Given this list of marker genes YOD1, RPN2 (NCBI Gene Id 6185), PSMB6, CORO1B, RPS26, TSPAN13, CTRB2, RUBCNL, NKAPD1, AKAP1, MYBBP1A, GID4, SNRPB2, RPE, CD1D, ERAP1, SLC5A2, U2AF1, GM2A, JADE3, CERS6, TUT4, GIMAP5, PDGFRA, PAICS, BAX, TAGLN2, SCGB2A2, AGRN, CD177, H2BC6, BTNL2, NDUFC2, BID, ZNHIT3, ANKRD17, TANC2, TCOF1, GATA6, CYP3A43, RGS12, GPA33, GAK, NF2, ACTR1A, PDLIM1, GZMA, GBE1, PABPN1, RFX2, ISG20L2, PEF1, DNAJB4, DKC1, CSK, KIR2DS5, CROCCP3, WRN, HDAC2, RAD23A, MAGED2, TOB1, ARR3, PLAGL1, GNAI1, LIF, NCF1C, TFPI, KCTD5, YARS1, BBLN, ADRB3, AP3S2, TENM1, SERPINC1, DAAM1, GTPBP1, EEF1E1, NREP, COX6C, FRMD4A, ZKSCAN7, RANBP10, RNASET2, H1-2, SIDT2, PLAC8 (NCBI Gene Id 95621), IPPK, MARCKS, H4C11, PRRC2B, CBX2, LINC01587, FAM3C, UBB, NR0B2, DGCR5, OTUD4, IFITM3 (interferon induced transmembrane protein 3), SMARCC1, GCFC2, NR2E1, EHD4, CARF, TCF4, EML2, CD19, KDM4A, TTK, BRD3OS, KAZN, BCL11A, HEG1, ADIPOQ, UPP1 (uridine phosphorylase 1), ARHGEF5, FGD1 (NCBI Gene Id 2245), LCN1, PRR36, SCGB1D2, CPEB3, MAST4, TFDP1, GAL3ST4, KRT38, HLA-DQA1, TMEM33, MAGEH1, COL19A1, IFNGR2, OR7E36P, CHST2, PTPRT, PCMTD2, P4HA1, KRT12, OSBPL11, PLOD2, SH2D1A, MCL1, NEURL1, BACH1, H2BC12, NOP10, PRELP, PI4KB, TMEM45A, HTR2B, SDHC, ATG4B, ZNF493, DPYD, SMC4, HSPH1, GGCT, HPGD, ZBTB39, IVD, PLEKHF2, DAZL, HSPA1A, TNFAIP3, RBX1, RYR2, PTH1R, RBBP8, ANKRD55, SLCO4A1, CCN1, SAP30, VPS13C, YBX3, AFF1, UFL1, NCK2, RBL2, PCOLCE, POLE, B4GALT1, GDPD3, HS2ST1, MMD, MTCL2, SCRN1, LYPLA1, PSORS1C2, ID2, PLSCR1, CCN6, RACK1 (NCBI Gene Id 90938), EZH2, SNRPF, XPNPEP1, IMPA1, GABRA3, EHD3, ATF1, here is a description of the gene set: Genes up-regulated in CD4 T cells from cord blood versus those from adult blood. Human Gene Set: GSE1460_CORD_VS_ADULT_BLOOD_NAIVE_CD4_TCELL_UP from publication Lee MS, Hanspers K, Barker CS, Korn AP, McCune JM (PMID 15210650) Subpopulations of human fetal thymocyte and circulating naïve T cells were obtained through FACS sorting, including CD3-CD4+CD8- intrathymic T progenitor cells (ITTP), CD3intCD4+CD8+ \double positive\ thymocytes (DP), CD3highCD4+CD8- \single positive\ thymocytes (SP4), CD3+CD4+CD8-CD45RA+CD62L+ naive T cells from cord blood (CB4+), and CD3+CD4+CD8-CD45RA+CD62L+ naive T cells from adult blood (AB4+). studied in species Homo sapiens